Given this list of marker genes GNAS, TP53, PRKAR1A, TRMT10A, ARMC5, ADRA2A, PRKACA, ALMS1 (ALMS1 centrosome and basal body associated protein), PPP1R15B, CDH23, ATRX, NR3C1, PDE11A, BRAF (B-Raf proto-oncogene, serine/threonine kinase), USP8, USP48, KDM1A, here is a description of the gene set: An area of fat accumulation at the back of the neck in the form of a hump. Human Gene Set: HP_DORSOCERVICAL_FAT_PAD Dorsocervical fat pad species: Homo sapiens